Given this list of marker genes Gstm7, Alox12b, Gstm1, Gstm3, Gstm6, Gstp3, Alox15, Aloxe3, Gstp-ps, Gstp2, Alox8, Gstp1, Gstm2, Alox12, here is a description of the gene set: Mouse Gene Set: GOBP_HEPOXILIN_METABOLIC_PROCESS The chemical reactions and pathways involving hepoxilins, a class of bioactive icosanoids with roles in the regulation of cell physiology. species: Mus musculus